Given this list of marker genes Lrrtm3, Mzb1, Uts2r, Pou6f1, Tnnc2, Cnn1, Chst1, Kcnj9, Pde6b, Adcy6, Xirp1, Optc, Tnf, Hpca, Tmem255a, Th, Dusp8, Pcdhb13, Fxyd7, Hoatz, Mc3r, Sftpc, Lrrc4b, Col24a1, Zeb2, Nkx2-6, Cplx3, Myh11, Cyp8b1, Calcb, Rtbdn, Akp3, Neurl3, Tlr9, Parvg, Zic4, Lep, Prss16, Upk3a, Rnf112, Cfap57, Plekhg4, Kcng4, here is a description of the gene set: Genes with intermediate-CpG-density promoters (ICP) bearing histone H3 K27 trimethylation mark (H3K27me3) in embryonic stem cells (ES). from publication Mikkelsen TS, Ku M, Jaffe DB, Issac B, Lieberman E, Giannoukos G, Alvarez P, Brockman W, Kim TK, Koche RP, Lee W, Mendenhall E, O'Donovan A, Presser A, Russ C, Xie X, Meissner A, Wernig M, Jaenisch R, Nusbaum C, Lander ES, Bernstein BE (PMID 17603471) studied in species Mus musculus Mouse Gene Set: MIKKELSEN_ES_ICP_WITH_H3K27ME3 We report the application of single-molecule-based sequencing technology for high-throughput profiling of histone modifications in mammalian cells. By obtaining over four billion bases of sequence from chromatin immunoprecipitated DNA, we generated genome-wide chromatin-state maps of mouse embryonic stem cells, neural progenitor cells and embryonic fibroblasts. We find that lysine 4 and lysine 27 trimethylation effectively discriminates genes that are expressed, poised for expression, or stably repressed, and therefore reflect cell state and lineage potential. Lysine 36 trimethylation marks primary coding and non-coding transcripts, facilitating gene annotation. Trimethylation of lysine 9 and lysine 20 is detected at satellite, telomeric and active long-terminal repeats, and can spread into proximal unique sequences. Lysine 4 and lysine 9 trimethylation marks imprinting control regions. Finally, we show that chromatin state can be read in an allele-specific manner by using single nucleotide polymorphisms. This study provides a framework for the application of comprehensive chromatin profiling towards characterization of diverse mammalian cell populations.